The following is a description of a gene set: Genes containing one or more binding sites for (Smarca2) in their promoter regions (TSS -1000,+100 bp) as identified by GTRD version 20.06 ChIP-seq harmonization. Mouse Gene Set: SMARCA2_TARGET_GENES species: Mus musculus from publication Yevshin I, Sharipov R, Kolmykov S, Kondrakhin Y, Kolpakov F (PMID 30445619), and this is the list of marker genes: Actl6a, Rpl18a, Ankrd35, Itgbl1, Mras, Zbtb44, Lrrk2, Srsf7, Mrnip, Msh6, Mir302b, Senp5, Anapc5, Slc39a13, Unc13a, Phb2, Nop14, Gm29340, Snord104, Gcnt2, Large1, Prnp, H3f3b, Tbc1d15, Etnk1, Glipr2, Prdx3 (peroxiredoxin 3), Agps, Adprs, Mtf2, Mtcp1, Gm25336, H4c8, Pkn3, Mobp, Maml1, Myo18a, Lrch1, Gls, Dusp1, Taf5, Gm22711, Emg1, Dedd, Upf3a, Mir302a, Dhcr24, 1700041G16Rik, Yars2, Grk4, Pdss1, Mrpl15, Foxj3, Tbrg1, Ehd1, Epcam, Patj, Colec12, Aunip, Nodal, Slc9a1, Tmem131, Ttc39d, Tnk2, Mir5122, Hmgxb4, Gm19426, Cmc4, Frg2f1, Ccnb1ip1, Gpr19, Fchsd2, Nudt1, Ddc, Sema4b, Gm11335, Caprin2, Erc2 (NCBI Gene Id 52497), Tob1, Cradd, Uchl1os (ubiquitin carboxy-terminal hydrolase L1, opposite strand), Rfx7, Pphln1, Slc39a3, Tpp2, Itprid2, Rpl7l1, Snora17, Ddx39a, Mir7b, Btaf1, Ap1m1, Nrbf2, 2700078F05Rik, Gtf2a1, Hsd17b14, Chrnb2, 2410021H03Rik, Eno1, Gm12100, Gm14022, Barhl1, Prn, Ly6e, Rab33b, Rbm4b, Esf1, Lrp2 (low density lipoprotein receptor-related protein 2), Tdrd12, H2bc4, Tob2, Arhgef2, Nhsl1, Mtrf1l, Calcoco2, Arap2, Srsf6, 4930509E16Rik, Ago1, Ndufaf5, Stag3, Txnip, Gjc1, Mrm2, Wdtc1, B3gnt2, Clcn3, Snhg7os, Wls (NCBI Gene Id 99763), Gm26479, H2ac6, Chka, Vapa, Mtss1, Sgms2, Pgam1, Trap1, Cdca3, Vegfc, Slc8a2, Abhd11, Ccn2, Nup54, Gpc2, Cox5a, Mideas, 1700113A16Rik, Samm50, Rab5if (RAB5 interacting factor), Zbtb7b, Hipk2, Ufl1, Mir302c, Vamp4, Nop56, Gm15417, Met, Tomm7, Arfgap1, 5430405H02Rik, Haspin, Cbx1, Uchl1, Necab1, Brcc3, Stat3, Epb41l4b, Tsku, Vamp1, Trim59, H1f2, Eef1a1 (eukaryotic translation elongation factor 1 alpha 1), Septin11, Usp5, B230317F23Rik, Gm12514